Given this list of marker genes SHROOM2, ADORA3, MYCBP2, PEX10, FAM20C, here is a description of the gene set: species: Homo sapiens from publication Chen Y, Wang X (PMID 31504780) Human Gene Set: MIR1247_5P Genes predicted to be targets of miRBase v22 microRNA hsa-miR-1247-5p in miRDB v6.0 with MirTarget v4 prediction scores > 80 (high confidence targets).